The following is a description of a gene set: Mouse Gene Set: GOMF_LYSOPHOSPHATIDIC_ACID_BINDING Binding to lysophosphatidic acid (LPA), a phospholipid derivative that acts as a potent mitogen due to its activation of high-affinity G protein-coupled receptors. species: Mus musculus, and this is the list of marker genes: Ppt1, Gap43, Vil1, Pnpla3, Lpar1, Lpar4, Tpp1, Cln6